The following is a description of a gene set: Any process that modulates the frequency, rate or extent of attachment of spindle microtubules to kinetochore involved in mitotic sister chromatid segregation. species: Mus musculus Mouse Gene Set: GOBP_REGULATION_OF_ATTACHMENT_OF_MITOTIC_SPINDLE_MICROTUBULES_TO_KINETOCHORE, and this is the list of marker genes: Hnrnpu, Cdca8, Sirt1, Incenp, Birc5, Kat5, Kat2b, Becn1, Cdk1, Aurkb